Given this list of marker genes RASGRP1, FEM1B, HEG1, CENPE, XRCC6, LATS2 (large tumor suppressor kinase 2), PDGFB (NCBI Gene Id 5155), SOCS4, RBL2, CCNY, ABL1, TNFSF15, XRCC1, MAP2K2 (NCBI Gene Id 85511, mitogen-activated protein kinase kinase 2), ERN1, TRAF4, DYNAP (dynactin associated protein), MAP4K2, MVP, DBI, CHP1, PAQR3, GTF2H1, RPS7 (NCBI Gene Id 6201), FBXO5 (NCBI Gene Id 26271), PCNA, MMD2, RASSF2, CDC20, ZNF16, DSCC1, S100A12, HERC5, MYCNOS, DDR2, TFAP4, GAS6, SFN, EREG, BLM, GSKIP, LDB1, CD4, PLK1, LCP2, LYN, MAD2L1, UBE2S, MT3, SYNPO2, DOK7, DSTYK, TLR6, PTK6, ZFYVE28, SRC, MACROH2A1, CCNG1, RAPGEF2, DIRAS2, ADARB1, TNF, CDC14B, PPIA, CHI3L1, PIM1, CCNT1, NLRC5, DIRAS3, ADCYAP1, PDGFRB, SERPINB3 (NCBI Gene Id 96249), DUSP7, EMP2, TRIB2, TSPYL2, CALCA, LMO4, PKMYT1, MIDN, SKP1, CEACAM1, JTB (NCBI Gene Id 23561), MAGEC2, MAD2L2, WARS1 (tryptophanyl-tRNA synthetase 1), PTPN1, BANF1, STRADB, RTRAF, CDK5R1, PDCD10, PRLR, FGF2, RBL1, TNFRSF10B, AGAP2, UNC119, GSK3B, LDB2, HNRNPU, POLG2, LTF (lactotransferrin), IRGM, JAK2, PRKCD, MST1, RB1, CDK5RAP1, JMJD8, PIK3CG, CDKN1C, CDKN1B, ACP4, STK38, SNX6, PDCD4, ZNF622, SNF8, FGF18, TPD52L1, INCA1, BMI1, UVRAG, CASS4, CEMIP, SERTAD1, CSF1R, ADIPOQ, SYAP1, LILRA5, CIB1, PIBF1, PTPRJ, PRKN, BAG5, GSK3A, CHTF8, MAP3K5, STRADA, MRNIP, CDC25C, FZR1, NPM1, ADAM17, CAB39, FBN1, MAP3K7, PUM3, RPS2, STOX1, ERRFI1, AGT, MST1R, LAT (NCBI Gene Id 27040), UBE2C (NCBI Gene Id 11065), YWHAG, CORO1C, PYCARD, CLSPN, SRCIN1, FGFR1, FIRRM, ALS2, TSG101, IFNG, ECT2, CDKN3, PKIA, CDC37, PPM1E, MAPK8IP1, EEF1A2, MAP2K1, ELANE, CDC25A, GPRC5A, TOM1L1, BTRC, TRIM27, TAF7, TAOK3, CCNE2, RGS14, PAK2, LEP, XRCC5, CEP43, SNX9, CHMP6, MAGEA2, NPRL2, CDKN2A, EIF4A2, AIDA, CDKN1A, TAB2, RFC3, RPL11, PTPN22, RAP2B, RIPK3, SMG8, KSR1, CIMAP3, RAP2C, CEP85, CDK5RAP3, HIPK3, SPINDOC, PRKCH, DTX3L, NPPA, SASH1, DRD4, FGF16, FLT1 (NCBI Gene Id 2321), GPRC5B, TARBP2, MAP3K4, RASIP1, PABPN1, IGF1 (NCBI Gene Id 3479), PILRB (NCBI Gene Id 29990), CCDC88A, ARRDC4, MAP3K10, MAGEA2B, CARD10 (caspase recruitment domain family member 10), VPS25, RALB, PIH1D1, ZGPAT, KIF14, LATS1, APOE (apolipoprotein E), DBNDD2, SPDYA, FLT3, CHTF18 (NCBI Gene Id 64722), PLAAT4, RAP1A, NEK10, ADAR, SOCS5, ARRDC3, TRIB1, DEFB114, TRAF6, NEDD9, HLA-DRB1, PTK2B, TCIM, RFC2, CD74, DUSP1, PPP1R3F, CACUL1, ITGB1BP1, TNFRSF10A, TIGAR, FEM1A, THY1, APC, TRIB3, ETAA1, DIPK2A, BCCIP, FGR, CCNK, USP44, FGF1, MARCHF6-DT, NRG1, TENM1, CDK5R2, DEPTOR, PTPRC, RPL5, TLR3, CDC6, ZFP36, PSMD10, RHOA, PIK3R5, EZH2, WNT5A, MEN1, SIRT1, MAP2K3, AKT1S1, DIRAS1, DNAJA1, PTK2, COPS8, CD300A (NCBI Gene Id 11314), RFC5, GADD45A, RPL23, ERBB2, ABI1, HPF1, STK11, RFC4 (NCBI Gene Id 5984), ADCY8, TPX2, GCKR, ZFP91, ANGPT1, PIK3R6, HMGA2, CCNT2, ARHGEF5, CARD14, MAP3K11, MMD, CDK12, CRIPTO, HGS, CAMK1, NHERF1, TRAF2, CAMKK2, PRDX3, here is a description of the gene set: species: Homo sapiens Any process that modulates the frequency, rate or extent of transferase activity, the catalysis of the transfer of a group, e.g. a methyl group, glycosyl group, acyl group, phosphorus-containing, or other groups, from one compound (generally regarded as the donor) to another compound (generally regarded as the acceptor). Transferase is the systematic name for any enzyme of EC class 2. Human Gene Set: GOBP_REGULATION_OF_TRANSFERASE_ACTIVITY